The following is a description of a gene set: Binding to fucose, the pentose 6-deoxygalactose. studied in species Mus musculus Mouse Gene Set: GOMF_FUCOSE_BINDING, and this is the list of marker genes: Clec10a, Colec11, Acr, Fuom, Asgr2, Mgl2, Selp, Asgr1